Given this list of marker genes EREG (epiregulin), PCDH7, PIK3CA, PPT2, SLC44A1, ZCCHC10, PRKCI (protein kinase C iota), NAA15, METAP1, M1AP, ARHGAP8, SLC38A3, C1orf52, RABGEF1, RAD21 (RAD21 cohesin complex component), KYNU, RAB38, EPHB4, RALB, INTS12, ACAD10, ACBD3, PMEPA1, PURB, LRRC59, APBB2, NOC3L, CD72, HINFP, CTU1, RBM15B, CRBN (cereblon), AOAH, TSHZ1, IGF1R, LTV1, SAP30, ZNF22, TMC2 (transmembrane channel like 2), HMGN5, PLAGL1, GSTA5, CAPN5, NECTIN2, CDC73, CKB, SNX10, WSB2, C8orf33 (NCBI Gene Id 65265), GUCY2C, TDO2, SFMBT1, PALS1, JDP2, LY96, AKT3 (NCBI Gene Id 26068), PPIF, PPP1CB, VASP, NFKB2, PDZK1IP1, EDEM3, OR10A4 (NCBI Gene Id 81350), HBB, PTPRZ1, SNTA1, SMU1, TRA2A, STK39, DYNC1I2, FKBP9, BBLN, BCKDHB, ITGAL, LPAR1, SHF (Src homology 2 domain containing F), RILPL2, MAGEH1, TSPAN1, AZIN1, TPR, ISG15, PROS1, SLC15A2, AHR, BMP15, RAB12, CCT3, PSME3, TLR8, DNAJB11, POLR3D, NMNAT1, CPEB3, IQGAP3, PDCD4, CIAO2B, CCL22, GSTM2, STARD8, ACYP1, ACSL1, GPR37, CBX4, CACNA1A, AZI2, PHF8, SURF4, MMP12, TM9SF4, PSMD6, COL4A2 (collagen type IV alpha 2 chain), IGSF9, EIF1AX, GADD45B, ACOT9, EIF1AY, CS, HBEGF, COCH, MED28, NPTX2 (neuronal pentraxin 2), SAR1A, CD200, HADHB, ACSL5, TEX12, CDH6, CCDC71, KDR, SCLY, RNASE3, PTPN11, GAS7, IKZF4, ORM1, ETS2, PLPP1, NUP160, NMU, SGCB, PIK3AP1, CALCRL, ALDH1A2, ENDOD1, ARL8A, FNDC3A, FAM20C, ASF1A (NCBI Gene Id 25842), FARSA, CCL17, PSMC4, QPCT, CEMIP2, NCOA5 (nuclear receptor coactivator 5), GRIN1, RAP1B, KCTD10, B3GNT2, TUFM, LCN2, CTLA4, ELP5 (elongator acetyltransferase complex subunit 5), ACLY, PIKFYVE, RPE, UBAP2L, APLP1, DNAJB5, NTS, UBE2E2, TCAF2, UBE2M, CDC42EP3, BARX2, HSD17B3, SNRPD3, LY75, CCNB3, SH3BGRL2, SPTLC2, PARP9, CCDC86, CD247, RELA, TLE4, FOXJ1, TXNL1, PPTC7, CDC27, PRMT6, TMEM115, ITGB1, ICOS, FXYD1, PILRA, HSPA1B, SEC63, SEH1L, ZNF689, here is a description of the gene set: mouse primary BMDCs were stimulated with tlr ligands and gene expression changes were profiled on Affymetrix arrays studied in species Homo sapiens Genes up-regulated in comparison of dendritic cells (DC) stimulated with LPS (TLR4 agonist) at 4 h versus DC cells stimulated with poly(I:C) (TLR3 agonist) at 4 h. Human Gene Set: GSE17721_LPS_VS_POLYIC_4H_BMDC_UP from publication Amit I, Garber M, Chevrier N, Leite AP, Donner Y, Eisenhaure T, Guttman M, Grenier JK, Li W, Zuk O, Schubert LA, Birditt B, Shay T, Goren A, Zhang X, Smith Z, Deering R, McDonald RC, Cabili M, Bernstein BE, Rinn JL, Meissner A, Root DE, Hacohen N, Regev A (PMID 19729616)